The following is a description of a gene set: from publication Chen Y, Wang X (PMID 31504780) Genes predicted to be targets of miRBase v22 microRNA hsa-miR-6511b-5p in miRDB v6.0 with MirTarget v4 prediction scores > 80 (high confidence targets). studied in species Homo sapiens Human Gene Set: MIR6511B_5P, and this is the list of marker genes: MAPK8IP2, SNX18, RBPJ, TWIST1, MAP6, SORBS2, RAB33A, DICER1, ZNF273, SLC25A20, ABLIM2, CACNA1E, EXO1, TOGARAM1, ACER3, MAF, LRATD1, CCDC149, RCOR1, ITGB7, ZNF384, ITGAL, ZNF280B, KRT20, ERLIN1, VIP, TMEM98, ANKRD29 (ankyrin repeat domain 29), SOST, FBXO17 (NCBI Gene Id 79967), POM121, TNRC6B, CD8B, CCND2, KLF3, CMTM4, BNC2, ZNF254, MTREX, FLVCR2, HECW2, UNC5C, TRIM74, PDCD6IP, DLST, FCER1G, SFMBT1, CYP4A22, FBXW7, LRP12, KCNA2, TDRP, HECTD1, VAMP3, KIF3B, IFNG, MED13, TRIM73, PRRT2, TCL1A, DEPDC1B, KRT76, MKNK1, BCCIP, SCNM1, RNF39, SOAT2, PACSIN2, TET1, AGFG1, EXOC6B, ZNF117, ENC1